The following is a description of a gene set: Genes down-regulated in macrophages (6h): IL4 versus IL4 and rosiglitazone. from publication Szanto A, Balint BL, Nagy ZS, Barta E, Dezso B, Pap A, Szeles L, Poliska S, Oros M, Evans RM, Barak Y, Schwabe J, Nagy L (PMID 21093321) studied in species Homo sapiens Human Gene Set: GSE16386_IL4_VS_IL4_AND_ROSIGLITAZONE_STIM_MACROPHAGE_6H_DN Human CD14 positive monocytes were purified from healthy volunteers’ blood and cultured in vitro for 6 hours. While culturing, macrophages were activated alternatively with interleukin-4 (IL-4 100 ng/ml). Simultaneously, macrophages were also treated with vehicle (DMSO:ethanol) or 1uM synthetic PPARg agonist, Rosiglitazone. We used Affymetrix microarrays (U133Plus 2.0) to analyze activation and PPARg-induced gene expression changes., and this is the list of marker genes: EPHA7, LRRC10B, CHRAC1, CRYBG3, OPCML, TMEM229A (transmembrane protein 229A), SEPTIN2, STEAP1, MARF1, TCHHL1, MYCBP2, SLC22A14, KIF26A, MLC1, HMMR, CLXN, CRABP1, NRIP3, CTTN, GAB1, SLC35D2, MAT1A, GRIA2, UTP11, PIGX, MCCC1, CHODL, FTCD, KNSTRN, KIAA1549L, LARGE1, TINAG, TDRD9, CLDN18 (claudin 18), COX14 (NCBI Gene Id 84987), PSRC1, MBD5, GJD2, PNMT, CUX2, SPATA7, RGCC, ATP2B3, NEB, CAPN6, FBLN1, VIL1, BRINP1, PSENEN (presenilin enhancer, gamma-secretase subunit), GLIPR1L1, ADAD1, NMNAT1, CRELD1, GPR34, CNGA2, AMMECR1L, SIRT4, ORC3, CCAR1, INSL5, OLFM3, TERB1, HDDC3, SYT9, CSDC2, SLC38A9, GML, PAX7, ZCCHC3, PHYHD1, FEZ1, CCN1, CCDC54, CEL (NCBI Gene Id 1056), C11orf97, SFSWAP, NR3C1, MN1, TBC1D32, NAV1, GABRB3, CDC26, MSANTD1, ZNF292, KCNV2, TSPAN32, PRPF38A, SLC23A1, CCN2, SLC41A1, SUGT1, FAM227B, MICOS13, CYP11B1, ACTC1, F8A1, TASL, PLEKHA7, IFNB1, FTMT, CCN4, WWTR1, KRT86, ATP10B, SDCCAG8, LRRC39, FOXO3 (NCBI Gene Id 2309), CTSE, CCDC87, BPIFB2, RNASET2, EQTN, FPR3, IL7, OSMR, OTOG, RPL26, CLMP, ABCC8, PIWIL4, MMP16, THSD1, CXCL13, USE1, FBXO36, KCNE3, VAMP3, TTC32, HACD2, CIMIP6, EMG1, TAC1, CDCA2, ZNF558, CDK1, HCAR2, ASB4, SYT4, COL4A1, CFAP52, SHISA2, CXCL2, NEK5, OTOS, LRRC3B, INSYN2B, NALCN, HOXB1, RPF2, RBP7, KRT2, EIF2D, TMEM181, PRC1, VEGFC, MGAT5, CKS2, CPA2, CTNND2, CA7, SERF1A, CDC20, SON, DPP10, NFAM1, PEX11A, SLC25A20, MME, POLN, PLCB1, REXO5, USP29, PLA2R1, DEPP1, NIPSNAP3B, SPATA19, GJB5, NUDT7, OR2T33, BCL2L10, POMT1, KALRN, CKAP2, B3GAT3, APOBEC2, KCNN2, CLDN12, MTF1, NMNAT2, KCNJ15, SENP7, NAALADL2, SLC25A34, C3orf18, TCEAL7, WNT3, SLC7A13, NTHL1